Given this list of marker genes SMC1A, REC8, ESCO2, PPP2R5D, SGO1, PLK1, SMC1B, STAG2, PPP2R5C, MAU2, APC, NIPBL, PPP2CA, CDK1, CDCA5, AURKB, PPP2R1A, SGO2, ESCO1, PPP2R1B, PPP2R5E, ESPL1, WAPL, PPP2R5B, STAG3, PPP2R5A, PDS5A, PTTG1, HDAC8, SMC3, PDS5B, PPP2CB, PTPA, RAD21, here is a description of the gene set: Human Gene Set: WP_COHESIN_COMPLEX_CORNELIA_DE_LANGE_SYNDROME species: Homo sapiens Cohesin complex - Cornelia de Lange syndrome